Given this list of marker genes PPP1R1A, CDKN1B, CAST, NGF, PABIR1, WFIKKN1, SERPINB6, HTRA2, DYNLL1, PPP1R37, CCAR2, RPTOR, PPP1R14D, C1QBP, SERPINA5, SPINK13, DUS2, SPINK6, ITIH3, ELFN1, SPP2 (NCBI Gene Id 6694), PINLYP, HSPA5, BSN, SERPINA12, SPINK2 (NCBI Gene Id 6691), SMCR8, WFDC10B, RCAN1 (NCBI Gene Id 1827), SERPINF1, GCKR, A2M, PLN, SERPINE1, PPP1R36, INCA1, LGALS3, XIAP, LRP6, CSTL1, HMSD, USP14, UGT1A1, WFDC1, TRIB2, SPINT2, IQGAP1, MLDHR, COL6A3, PPP1R12B, C4A, EPPIN, CTNND1, C4B, IQGAP2 (NCBI Gene Id 10788), UGT1A6, CABP1, CARD16, HSPB1, SPINK1, KNG1, WFDC8, PARVA, WFDC5, SERPINA11, SERPINF2, PREX2, MAPK7, TIMP2, PPP1R10, OTUB1, HDAC6 (histone deacetylase 6), PKIG, SKI, KAT2B, GBP5, NCK1, SLCO1B3, PROS1, CAMK2N1, NLRP7, TIPRL, CRB2, CIP2A, ADGRV1, MGAT5, PPP4R4, URI1, FBXO5, PZP, SPINK4, ACD, CST8 (NCBI Gene Id 10047), ITIH2, SMR3A, LXN, RARRES1, SPOCK1, CIT, MRLN, CST11, PPP2R5A, PPP1R8, PPME1, PARP9, GRM7, NAIP, LILRB4, NOTCH1, UGT1A4, PRKRIP1, CST9L, CST6, PI16, SERPINB3, BIN1, SERPINA7, PRPSAP2, PHACTR2, ANXA8, ANXA5, PPP1R26 (NCBI Gene Id 9858), PPP1R2P1, TFPI, HYAL2 (hyaluronidase 2), SERPINB8, SOCS1, SPINT4, OAZ2, CST7, IBTK, ANP32E, CARD17P, CST2, HRG, PPP1R17, SPOCK3, PI15, FAF2, UGT1A9, ANKRD42, PPP1R16B, NHERF4, C3, PPP1R9B, PI3, IGFBP2, TEN1, ATP2B4, PPP1R14B, CST9LP1, PPP1R11, INKA2, TXNIP, DNAJC3, ITIH1, RECK, SIMC1 (SUMO interacting motifs containing 1), APP, PRKCH, RPS15, RTKN, UGT1A10, TRIB3 (tribbles pseudokinase 3), SERPINA9, AHSG, TPRN, CSN2, SERPINC1, UGT1A8, SPRY4, APLP2, SH3BP5, PHACTR1, UCHL5, PPP1R35, FETUB (NCBI Gene Id 56684), PPP1R2B, C3P1, DUSP22, SPOCK2 (SPARC (osteonectin), cwcv and kazal like domains proteoglycan 2), CST1, YWHAE, PPP1R1C (protein phosphatase 1 regulatory inhibitor subunit 1C), AMBP, CRY2, SERPINA6, ANXA2P2, CD109, SLIT2, CAV1, LCN1, INKA1, WFDC3, PPP1R2, RPL37, MYOZ1, SLN, FURIN, SERPINA3, PIF1, PPP1R12C, PPP5C, LTF, RPS20, SERPINH1, PDE6D, SPRY2, PPP1R14C, RPL23, TMX1, CDC42SE1, WFDC12, SERPINA10, HSPBP1, SSPOP, UBE3D, COL7A1, RNH1, TIMP4, RACK1, DUSP19, PPP1R14A, SET, GCHFR, CSTA, SOCS3, SPRED2, RENBP, PPP1R2C, STYXL1 (NCBI Gene Id 51657), CABIN1, CDKN2A, SERPINA4, CRIM1, SH3RF2, MBIP, DDX21, UVSSA, PINX1 (NCBI Gene Id 91819), PRKAR1B, PABIR3, CPEB2, PARK7, PPP1R1B, SERPINB7, SPINK7, PRKAR2B, CDKN2D, ATP5IF1, LIMK1, KDM5A (NCBI Gene Id 5927), EGLN1, PREX1, TIMP3, WFDC2, BRAT1, DFFA, ITIH4, PCSK1N, TRIB1, ITIH6, PLA2R1, SPINK9, SERPINB12, DTX3L, SAG, PPEF2, APOC2, RPL5, A2ML1, GBP2, DUSP3, SERPINB10, PRKAR2A, SPINT3, PAPLN, THBS1, SLPI, R3HDML (NCBI Gene Id 140902), WFDC6, APOC3, BIRC7, SERPINI2, POT1, ANXA3, CHP1, SERPINB2, CDKN1A, CSTB, GAPDH, SMO, UGT1A7, FRY, ARRB1, GPS2, PRNP, CPAMD8, PRPSAP1, PSMF1, TESK1, NPM1, WFDC13, OAZ1, SERPINB11, SPRED1, SERPINI1, ANGPTL3, APBA3, PPP1R12A, SORL1, SFN, SCGB1A1, QARS1, DEPTOR, BST2, GNAI1, WFDC10A, ANXA1, TESC, UGT1A3, RPL11, ETFRF1, AGT, PDC, HEXIM2, ELFN2, SLCO1B7, RPS7, SMR3B, CLSTN3, MCRS1, STYX, COL28A1 (collagen type XXVIII alpha 1 chain), PTTG1, ANKLE2, GMFB, ITIH5, SERPINB5, LPA, SERPINB13, SPINT1, ENSA, TFPI2, MANSC4, PDE6H, ARHGAP5-AS1, PDE6G (NCBI Gene Id 5148), WARS1, SERPINA1, BOD1, CEP43, ANOS1, CAMK2N2, CDKN2B, CASP3, TNK2, AKT1, IFIT1, SERPINE3, GPC3, PRKAG2, ABCE1, C5 (NCBI Gene Id 727), SERPINA2, MACROH2A1 (macroH2A.1 histone), CIB1, OAZ3, WDTC1, APOC1, AKT1S1, PAK1IP1 (PAK1 interacting protein 1), PTN, RGS2, ITPRIP, GMPPA, SERPINE2, YWHAG, CST5, IPO5, BIRC5, SERPINB9, ARPP19, CST9, SPINK8, TIMP1, CST3, GMFG, OPRPN (NCBI Gene Id 58503), PABIR2, HSP90B1, COL4A3, GNAZ, APOA2, ERCC4, SIRPA, PTP4A2, CST4, ATAD3A (NCBI Gene Id 55210), SPINK14, SPINK5, CDKN2C, PKIA, UCN, PYDC1, SNCB, GLMN, CARD18, PKIB, ANGPTL4, WFDC9, GSKIP, PHACTR3, SERPINB1, SERPIND1, ANXA2, WFIKKN2, HEXIM1, PTPRC (protein tyrosine phosphatase receptor type C), PPP1R27, SCG5, SLCO1B3-SLCO1B7, PHPT1, SNCA, PPP1R16A, GSTP1, SH3BP5L, MAPK8IP1, BIRC6, PRKAR1A, FLCN, UMODL1, TMBIM6, GPS1, TAOK3, SERPINB4, PEBP1, EZHIP, LRRK2, SERPING1, ANXA4, CDKN1C, RHOH, LMTK2 (lemur tyrosine kinase 2), BAG5, YWHAB, WFDC11, here is a description of the gene set: Human Gene Set: GOMF_ENZYME_INHIBITOR_ACTIVITY species: Homo sapiens Binds to and stops, prevents or reduces the activity of an enzyme.